The following is a description of a gene set: Mouse Gene Set: GOBP_POSITIVE_REGULATION_OF_DNA_METABOLIC_PROCESS Any process that activates or increases the frequency, rate or extent of the chemical reactions and pathways involving DNA. studied in species Mus musculus, and this is the list of marker genes: Pml, Eya1, Epc1, Npm1, Arrb2, Meaf6, Jun, Parn, Timeless, Atm, Htr2a, Ifng, Dmap1, Smarcc1, Chtf8, Fancb, Top2b, Acd, Ino80d, Setmar, Cct4, Nek7, Mre11a, Khdc3, Brd8, Prkcq, Babam2 (BRISC and BRCA1 A complex member 2), Dscc1, Ptges3, Smarca4, Terc, Uimc1, Crebbp, Spidr, Cebpg, Tigar, Smarce1, Pak3, Shld3, Il4, Dbf4, Parp1, Ing3 (inhibitor of growth family, member 3), Tbx21, Slx4, Xrcc1, Ino80c, Dpf2, Igfbp3, Tmem161a, Slf1, Faf1, Cdk1, Baz1a, Cyp1b1, Hmgb1, Ercc2, Nvl, Stk19, Nbn (nibrin), Ddx11, Rtel1, Yeats4 (YEATS domain containing 4), Actl6b, Mtnap1, Pot1b, Mbtd1, Mrgbp, Was, Egfr, Rac1, Tgfb1, Myc, Peli1, Eya4, Smarcc2, E2f8, Ciz1, Brd7, Ercc6, Rfc3, Pnkp (polynucleotide kinase 3'- phosphatase), C3ar1, Ube2b, Fbxo4, Ankrd66, Ctnnb1, Epc2, Pdgfb, Mad2l2, Prkdc, Exosc3, Vegfa, Clcf1 (cardiotrophin-like cytokine factor 1), Naf1, Gnl3, Bcl7b, Kat7, Actr5, Zcwpw1, Parg, Mapk1, Rfc2, Smarca5, Wrap53, Ube2n, Atad5, Ctc1, Yy1, Hmces, Fgfr1, Nfatc1, Fgfr4, Klf4 (Kruppel-like transcription factor 4 (gut)), Lpin1, Potefam3a, Npas2, E2f7, Endog, Gch1 (NCBI Gene Id 14528), Smarcd3, Arid2, Aurkb, Crhr2, Ptprc (protein tyrosine phosphatase receptor type C), Dkc1, Sirt6, Cct7, Hmbox1, Ruvbl1, Kdm4d, Gli2, Rnf126, Cdc42, Fgf2, Pot1a, Stat6, Egf, Ucn, Spire1, Msh2, Hnrnpa2b1, Dpf3, Eya2, Rnf8, Il2, Brca1, Atrx, Brpf3, Tinf2, Phf10, Map2k7, Rad50, Parp3, Cct3, Smarca2, Map3k4, Tcp1 (NCBI Gene Id 435546), Rnf168, Fam168a, Eya3, Wiz, Wnt3a, Gfer, Arid1a, Actb, Smarcd2, Abraxas1, Cst3, Akt1, Mlh1, Mrnip, Babam1, Foxm1, Hsf1, Cd40, Prkd2, Ube2v2, Hras, Apbb1, Xrcc5, Trim28, Ereg, Wdr48, Rad51ap1, Dhx36, Slf2, Fmn2, Ptk2b, Dna2, Trrap, Hnrnpd, Nfrkb, Pcna, Cdt1, Actr8, Uchl5, Shld2, Hgf, Rfc5, Ager, Tfpt, Pkib (NCBI Gene Id 19081), Smchd1, Prdm9, Mapk8, Morf4l2, Morf4l1, Ino80b, Terf2, Cct6a, Pbrm1, Prmt1, Pdgfrb, Terf2ip, Anxa3, Spire2, Cct8, Wrn, Tnf (tumor necrosis factor), Potefam3b, Helq, Il6, Shld1, Kat5, Tnks, Gsk3b, Mapk3, Dhx9, Tnfsf13, Camk2d, Npm2, Smarcb1, Actl6a, Mapkapk5, Igf1r, Nox4, Slx1b, Dpf1, Hdac10, Smoc2, Map2k4, Blm, Mcrs1, Mas1, Pias4, Ep400 (NCBI Gene Id 75560), Fus, Rif1, Kctd13, Cd28, Pms2, Stn1, Mapk15, Cbx8, Chtf18, Exosc6, Nsd2, Met, Ddx39b, Bcl7a, Bcl7c, Cct5, Nabp2, Vps72, Ppp1r10, Ruvbl2, Skp2, Cdk2, Cyren, Rgcc, Cacybp (calcyclin binding protein), Brcc3dc, Cdc7, Tfrc, Tnfsf4, Rfc4, Pagr1a, Ino80, Prkcg, Ercc8, Atf1 (NCBI Gene Id 635028), Ooep, Bax, Ssbp1 (single-stranded DNA binding protein 1), Fh1, Kmt5b, Gata5, Kmt5c, Nek2, Pnp, Sirt1, Prkcd, Actr2, Pfn1, Ccna2, Ccdc117, Ankrd31, Tnfaip1, Paxip1, Gli1, Fgf10, Ercc1, Brcc3, Cct2, Trp53bp1, Tnks2, Mgmt, Smarcd1, Terf1, Polg2, Oga, Atr, Hdgfl2, Rps3